The following is a description of a gene set: Human Gene Set: GOBP_POSITIVE_REGULATION_OF_CYTOPLASMIC_MRNA_PROCESSING_BODY_ASSEMBLY species: Homo sapiens Any process that increases the rate, frequency, or extent of the aggregation, arrangement and bonding together of proteins and RNA molecules to form a cytoplasmic mRNA processing body., and this is the list of marker genes: PAN3, CNOT1, CNOT6, CNOT6L, PAN2, CNOT2